Given this list of marker genes SERPINE1, KRT2, C1GALT1, KRTAP6-3, PODXL, TFCP2L1, MIR302A, SOX18, BLTP1, NKX3-2, DLX5, S100A7, IGF1, TOLLIP, GDF7, TNF, LHX1, KRT36, FGFR2, GSK3A, NRP1, ID1, PSAPL1, LAMB2 (laminin subunit beta 2), NKX6-1, TAGLN2, HPSE, CLIC4, KRT79, KRT27, KLF7, SCUBE1, KRTAP6-1, BARX1, KRT76, PELO, FRZB, RAB10, KRT6B, SPRR1B, KDM5B, ASXL1, SPRY1, ABCB1, VDR, BMAL1, MYD88, LIPN, CRYAA, TGM1, NR5A2, PTCH2, KRT82, DLG5, KRT14, AHI1, KRT16, DSP, KRT75, SLC9A4, CBR1, PRDM1, KRT31, MIR181A2, CLCN2, GATA1 (NCBI Gene Id 2623), NKX2-5, MYO9A, BASP1, NKX2-1, TPP1, DSG4, PAX2, IPO7, PLS1, IFT74, PDGFB (platelet derived growth factor subunit B), RAB1A, KCNE1, SGPP1, SPRR3, EDNRB, BCL11B, GDF11, VAX1, MINAR2, HNRNPH3, RARB, NME2, TNFRSF1A, MED1, TSG101, GSTA2, LIF, AMOTL2, MAF, LUZP1, BCCIP, GSDME, ACVRL1, SPRR4, TTC8, TJP3, KRT4, APOLD1, RAPGEF1 (Rap guanine nucleotide exchange factor 1), OPHN1, GDNF, KRT35, IFT80, CCND1, CEACAM1, S1PR3, SLITRK6, KRT24, LTA4H, FOXJ2, NOTCH2, SPRR1A, KLF15, TMEM100, PTK6, KRT7, SOSTDC1, TIE1, SPRED1, ETV4 (NCBI Gene Id 2118), KDR, TJP1, CD109, SHARPIN, GATA5, PTPRO, SLC39A2, MIR150, KCNQ1, KRT26, MESP1, ABI2, MYCN, UPK1A, SMO, CCDC88C, SLC4A7, CNN3, ACADVL, FOXN1, CDKN2A, ELF5, LCE1E (late cornified envelope 1E), MIR99B, PLCB1, FOXB1, WWTR1, FOXC1, NCOA3, PPP3CA, MIR181B1, KRT71, SCX, HOXA5, KRT1, ESR1, TBX3, TRIOBP, KRT34, DACT2, SPRR2F, ID3, BFSP2, IL13, CDH5, MIR518B, RDX, AIMP2, CPT1A, DSG2, IL31RA, CDH2, MAGI2, ZDHHC21, RILPL1, CDKN1B (NCBI Gene Id 1027), PAX4, SMAD2, NR5A1, KRT32, CRYGB, LGALS3, CDKN1C, TMEM132E, EXPH5, YIPF6, RHCG, SAV1, FOXH1 (forkhead box H1), MTSS1, TPRN, CEP152, ACVR1, BCR, CREB1, EDN1, KRT40, SMAD3, PTPRS, CITED1, VSIG1, HOXB13, ETV2, PYY, KRT39, LIPM, OVOL3, SOD1, FZR1, PLEC, TGFB1I1, ZEB2, TJP2, FOXP3, SPRED3, HES5, FZD5, SALL1, AGR2, CDH23, RAB13, ALDOC, STAT5B, COL18A1, GDF2, PKP1, PGK1, NR0B1, KRT37, HES1, FZD1, CDK1, CPS1, EPHA2, NRG1, OPN3, PAX8, ADIPOQ, GRHL1, KRT77, BMP5, CLDN5, ZNF800, VDAC1, ONECUT1, SCRIB, LHFPL5, FGF20, CAV1, KRT13, BMP6, OSR1, PKHD1, KRT38, NOTCH1, PROX1, WHRN, MCOLN3, KLF4, NTRK3, RAP2A, DMRT1, CD34, ERRFI1, TECTA, FGF2, FGF8, SLC4A5, IKBKB, CDKN1A, SCEL, KRT9, MIR200C, LCE2A, KRT86, CES1, REG3G, NOTCH4, GPX1, SPRR2E, BMP2, KRT28, TNMD, FAM20C, CRYGD (crystallin gamma D), GDF3, HSF4, SAFB2, CASP3, PRKX, POU4F3, OVOL2, MYCL, MAGI1, SPRR5, LCE3E, FZD2, TIGAR, MIR541, BMP7, ANKRD24, AKR1B1, RAP1A, ERCC3, NPPC, GLI1, OVOL1 (ovo like transcriptional repressor 1), ANXA1, PDPN, FASN, MIR204, AMPD2, IER3IP1, UGCG, GPR4, HDAC1, TMC1, TBX1, HEY2, MYO6, SPRY2, FSTL1 (NCBI Gene Id 65385), LIPK, ZNF703, LBH, PPP1R16B, FER, F2RL1, KRT6C, ATOH1, EPB41L5, AFDN, KRT17, BFSP1, WNT1, RAP1B, LCE1B (late cornified envelope 1B), TXNIP, STAT5A, PLOD3, KRT23, COL6A1, MYO1E (myosin IE), TAGLN, FOXF1, EPAS1, WT1, XDH (NCBI Gene Id 7498), SOX8, PROM1, F11R, IRF6, UPK3A, TBC1D20, LCE3D, GLI2, SLC9A2, RFX3, VCL, WNT5B, KLF5, YAP1, ZFP36, AJAP1, NKX6-3, MACROH2A1, JAG1, LCE2D, THRB, ALOX15B, FRMD6, FLNA, KRT10, THRA (thyroid hormone receptor alpha), NPHS1, AR, ROCK1, MYADM, SRC, GSTM3, MEF2C, ROCK2, HYDIN, BAD, KRT3, E2F7, DEUP1, NFKBIZ, KRT84, LCE1D, LCE7A, EXT1, MAP2K1, MIR495, IL20 (interleukin 20), RAP2C, CDX2, WNT10B, E2F4, WDR77, MIR199B, HAPLN2, PTER, PIH1D1, SPRR2D, HOXB5, COL4A1, MIR18B, RFX6, ROBO4, PPARG, SOX4, SOX9, LCE2C, HOXA13, FOXA1, MYO7A, ARHGEF26, BMPR2, TCF15, ARID4B, SULT2B1, RBBP9, PLAAT3, ANXA7, EREG, IL6ST, RBPJ, EDNRA, TRIM16, TMEM231, NR2F2, PTK7, CBFA2T2, FST, RAC1, CD24, ANXA4, CLOCK, FOXJ1, KRT20, TMOD1, NEUROD1 (NCBI Gene Id 7853), PECAM1, POU3F1, NKX2-6, NPHS2, AKT1, EDF1, VEGFA, FN3K, ACTL8, ERCC2, HSD17B4, ARID4A, KDM6B, ASCL1, CEBPB, LCE5A, ABL1, NHERF1, CDC42, GATA3, KRT73, PLK4, EZR, ELMOD3, SIX3, CTSB, DSPP, PIP5K1A, PPP3R1, PLAAT4, GSTA1, KRT81, PRKCH, UPK2 (uroplakin 2), MAFG, RAPGEF2, BHLHA15, ADAM7, FA2H, FOXL2, MARVELD2, RBM4, ATF4 (activating transcription factor 4), FZD7, TAF10, STRC, TUBB, FOXE3, NKX2-2, CD63, KRT72, ENAM, SPINT2, SMARCB1, NUMA1, SOX17, E2F8, CCM2, KRTAP6-2, BMP4, KRT78, GREM1, DAB2, PPP1R12A, ASAH1, VIM, PCK2, PCK1, SPRR2G, IQGAP1, S1PR2, IFNG, NKX6-2, ADAM9, LHX3, WDPCP, KRT19, PDX1, SIDT2, VIL1, PITX3, GRXCR2, B9D1, LCE4A, ERBB4, NODAL, SULT1B1, RILPL2, BDH2, WNT11, KLF2, FRS2, CD2AP (NCBI Gene Id 25916), STAT1, NPR2, NF2, ADAMTSL4, LCE2B, CCNO, INSM1, WNT7A, STC1, ATOH8, SYNE4, GRXCR1, KRT85, AQP3, NFIB, SFN, RAPGEF6, PAFAH1B1, HOXA7, KRT74 (keratin 74), MSI1, ADD1, SIPA1L3, SPRED2, FGFR1, ZFP36L1, ACTA2, SKIL, PALLD, PITX2, CDH3 (cadherin 3), AKR1C1, RAP2B, PERCC1, CLDN1, IL17A, PDE4D, RAB1B, HRNR, PSAP, LORICRIN, CLRN2, ICAM1, PDE2A, AKR1C2, RHOA, CDSN, TMEM38B, MCIDAS, SEC24B, USH1C, MSN, SPINK5, SH3BP1, KRT5, TCHH (trichohyalin), KRT83, RAB25, MET, FOSL2, B4GALT1, NTF4, DNASE1L2, TFAP2C, IVL, PGR, EXTL3, GATA4, ROS1, JUN, ATRX, CYP26B1, PDPK1, KRT6A, TST, SFRP4, KRT12, LATS1, VEZF1, STK4, USH2A, MIR1-1, EZH2, IL1B, LATS2 (large tumor suppressor kinase 2), RARA, BTG1, UPK1B, MIR29B1 (microRNA 29b-1), MMP9, CASP14, PPL, CTNNB1 (catenin beta 1), TGFB2, CLDN3, INTU, KRAS, LCE3C, TP63, TGFB1 (transforming growth factor beta 1), FOXI3, DHRS9, S1PR1, KAZN, HNF1B, TLR9, CNFN, FEM1B, TMEM79 (transmembrane protein 79), SMAD4, CLRN1, MIR10A, NFE2L1, MSX2, POU2F3, KLK5, CCDC78, SPDEF, RARG, CDHR2, CAMSAP3, FOXC2, ONECUT2, HIF1A, ZBED2, LCE6A, GSK3B, LEF1, IHH (Indian hedgehog signaling molecule), MAFF, WNT7B, ARX, GSTK1, FNDC3A, GPAT4, MAP1B (microtubule associated protein 1B), KRT80, NEUROG3, RAPGEF3, ID2, DNPH1, CEBPA, OTP, IFT20, MACROH2A2, CYP1A1, CDK6, DLX6, AKT2, NPY, MIR125B1, FSHR, FAM3C, SPRR2B, FGF10, TGM3, DLX3, SIX2, TCF21, AKR1C3, LCE1C, WNT4, SOX11, GATA6, PCNA, FAT1, REST, EVPL (NCBI Gene Id 2125), PAX6, MIR34A, HDAC2, GMNC, ZDHHC7, WNT16, FLG, XBP1, PRLR, REG3A, MAFB, MIR21, INHBA, LIPA, ESRP1, ST14, TP73, SETSIP, WNT5A, JAG2, CYP27B1, LCE3B, RHEB, SIX1, CASP6 (NCBI Gene Id 839), KDF1, LCE1A, PDZD7, PTCH1, EHF, LCE3A, CEP63, FLNB, TDRD7 (NCBI Gene Id 23424), ITGA2, HEY1, POF1B, NDP, PLAAT1, CERS3, KRT25, LCE1F, LAMA1, ZEB1, PROC, PPHLN1, WNT9B, EMX1, KEAP1, DMBT1, CSTA, ACER1, SLC44A4, KRT33A, NUP210L, ACVR2B, SRSF6, NTRK1, MSX1, KRT15, POU3F2, KRT33B, TMIGD1, RPTOR, GRHL2, FZD4 (frizzled class receptor 4), GATA2, ABCA12, HEG1, DLL1, here is a description of the gene set: Human Gene Set: GOBP_EPITHELIAL_CELL_DIFFERENTIATION The process in which a relatively unspecialized cell acquires specialized features of an epithelial cell, any of the cells making up an epithelium. species: Homo sapiens